The following is a description of a gene set: studied in species Homo sapiens Programmed Cell Death Human Gene Set: REACTOME_PROGRAMMED_CELL_DEATH, and this is the list of marker genes: BIRC2, IRF1, LMNA, FLOT1, APAF1, PMAIP1, PSMA5 (NCBI Gene Id 5686), GSDMD, PSMD7, VIM, GSN, E2F1, APC, PSMB5, ROCK1, TP63, PSMC3, CHMP2A, SEM1 (NCBI Gene Id 7979), YWHAH, RPS27A, BBC3, RIPK3 (receptor interacting serine/threonine kinase 3), ITCH, CASP5, BAD, H1-2, MAPK3, PTK2 (protein tyrosine kinase 2), CHMP6, PSMB6, CHMP3, OPA1, OGT, CHMP4C, UBE2L3, PSMD6, DFFB, PSMB7, SPTAN1, YWHAG, CFLAR, DBNL, UNC5A, GZMB, ELANE, MAPK1, OCLN, RIPK1, PKP1, HMGB1, STK24, AKT3, CASP8, APIP, CTNNB1, DSG1, TRADD, PSMC2, IL1B, TNFRSF10A, CASP3, FLOT2, TJP2, TP73, DAPK1, TICAM2, LMNB1, CHMP2B, BMX, PSMD11, H1-3, CLSPN, PDCD6IP, AKT1, PSMC5, CARD8, OMA1, STAT3, PSMA3, CASP7 (caspase 7), ADRM1, TP53BP2, CHMP4A, BCL2L11, PSMC6, UNC5B, PSMD13, C1QBP, BCAP31 (NCBI Gene Id 10134), BIRC3, H1-5, MLKL, PSMB2, ACIN1, DAPK3, BCL2L1, BCL2, TLR4, DSP, BMF, FADD, PSMA7, BAK1, PSMB1, DSG3, PPP3CC, SEPTIN4, TFDP1, TICAM1, ARHGAP10, CDKN2A, CDH1, UBC, FAS, H1-0, DYNLL2, PSMD12, PAK2, YWHAB, H1-1, TRAF2 (TNF receptor associated factor 2), TP53, CASP4, DNM1L, DCC, STK26, PSMD14, UACA, CD14, ADD1, PSMD1 (proteasome 26S subunit, non-ATPase 1), MAPT, FNTA, PSMD2, GAS2, DAPK2, DYNLL1, UBB, LY96, PSMC4, XIAP, PSMD8, BAX, CHMP7, MAGED1, GSDME, PSMD3, NMT1, SFN, CHMP4B, DIABLO, TFDP2, PPP1R13B, KPNB1, PRKCQ, SATB1, PLEC, CASP6, PSMC1, CASP9, IRF2, APPL1, TJP1, H1-4, MAPK8, HMGB2, TNFSF10, PSMA6, PSMA4, PSMA1, FASLG, PRKCD, IL18, AKT2, PELI1, DFFA, CDC37, KPNA1, PSMA2, PSMB3, UBA52, AVEN, PPP3R1, PSMB4, CYCS, SDCBP, IL1A, YWHAZ, DSG2, TNFRSF10B, YWHAE, YWHAQ, PRKN, HSP90AA1, BID, STUB1, CASP1